Given this list of marker genes PTGR3, GIPC3, CDCA4, TESK2, TIGD5, GAGE1, TNRC6C, TTC21B, NUP153, TRIM44, ARHGAP10, SMLR1, GDF11, LCORL, CCDC182, KCTD5, CYB5B, IGF2BP2, RIC8B, FAM120C, PDZD7 (PDZ domain containing 7), HYLS1, RBL2, PFN2, TIPARP, LSM6, TEAD3, NAV3, PDCD2, DPP8, ZCCHC14, TENT4A, NOCT, ELL2, LSM12, TSC22D2, RAD23B, PARP8, PID1, ATM, FBXO11, RPS20, ZNF641, LAMTOR3, RASSF8, MB21D2, ARPC1A, CACNA2D1, GPN2, LRIT2, MARCHF3, DRP2, CACNB4, CREG1, CHD6, LIMS3, OAS3, MCOLN3, ZHX2, PLD5, LIMS4, ORC2, TNN (NCBI Gene Id 63923), PPM1A, HS6ST3, OXNAD1, BACE1, here is a description of the gene set: from publication Chen Y, Wang X (PMID 31504780) Genes predicted to be targets of miRBase v22 microRNA hsa-miR-1287-5p in miRDB v6.0 with MirTarget v4 prediction scores > 80 (high confidence targets). Human Gene Set: MIR1287_5P studied in species Homo sapiens